Given this list of marker genes CAV1, SMAD4, YWHAE, YWHAQ, SFN, UBE2I, YWHAH, SMAD3, SP1, PSMC6, YWHAG, EP300, PDPK1, YWHAZ, SERPINE1, YWHAB (tyrosine 3-monooxygenase/tryptophan 5-monooxygenase activation protein beta), here is a description of the gene set: Human Gene Set: REACTOME_SARS_COV_1_TARGETS_HOST_INTRACELLULAR_SIGNALLING_AND_REGULATORY_PATHWAYS SARS-CoV-1 targets host intracellular signalling and regulatory pathways studied in species Homo sapiens